Given this list of marker genes CXCR4, UBA6, RAF1, RSBN1, SLC35A2, ST3GAL4, RAMP3, PPP1R15A, EIF1, TMEM109, DHCR7, MORF4L2, NT5C2, ELK3, EIF4A1, HNRNPK, UBE2V2, ETS2, PTGS2, SYVN1, ATG4C, WEE1, LAMTOR5, DLL4, PRKRA, LINC01160, MAP3K8, SOCS3, SFT2D3, EHD1, GCNT1, LASP1, CXCL3, RAB8B, TRIM35, NLK, DNAJC2, YME1L1 (YME1 like 1 ATPase), PABIR1 (PP2A Aalpha (PPP2R1A) and B55A (PPP2R2A) interacting phosphatase regulator 1), KATNBL1, OPLAH, EPS8, HMGCR, CDK2, IFT122, PPA2, IL6, TANC2, MTBP, FBXO11, IZUMO4, IL1B, CSRNP1, VAPA, LDLR, ST3GAL6, RLIM, NBEAL2, VPS51, LRCH1, LLCFC1, WDTC1, HMGA1, PPP2R5A (protein phosphatase 2 regulatory subunit B'alpha), NPLOC4, MATK, PHLDA1, UBA3, EPHA2, HSPE1, ABRACL, CH25H, PIP4P2, KRR1, PPIG, ADAM10, KHSRP, TIFA, PDE4B, VPS8, POLR3C, AFG3L2, MDH1, IER5, ATXN2L, EIF2A, ANXA11, SART1, GPR171, PCMT1, C9orf72, HK1, MLLT3, SERPINB2, TNFAIP3, NFKBID, USP25, TSPYL1, EEF1AKMT2, MPHOSPH9, PRDM1, ATP6V0D1, MSRB3, LCORL, SEPTIN7, CARNS1, DCLRE1A (NCBI Gene Id 9937), ZRANB1, COX11, GNB1, ENY2, GLIS3 (NCBI Gene Id 648268), NXT2, METAP2, RIOK2, MCM2, CDKN1B, RAI2, STK32A, ICAM1, ACTL6A, DNAJC24, GSK3A, ZNF830 (NCBI Gene Id 91603), USP24, RECQL, GEM, MYL9, MAFF, PCGF5, FAM83D, TNF, IRS2, HDAC9, LTA, GBF1, RNPC3, DHX9, GSTO1, ID2, TRAF1, TCOF1, HMGB2 (NCBI Gene Id 3148), GADD45A, MIDEAS, NFKBIB, SCO1, CD86, UFD1, SCRIB, GPR174, TXNRD1, CCDC90B, CCRL2, MAP3K3, IL12B, CHPF2, SAMTOR, BRD3OS, TRAFD1, H1-0, FNIP1, ZFP36, IQSEC1, MARCKSL1, RBM15, RRS1, FAM120A, PHF1, IL1RL2, RAB11A, RAB20, TGIF1, ATP11A, SLC15A3, SMG7, ENPP4, IQCB1, FOXN2, FNBP1L, EZH2, RAB11B, PIK3R2, ADAM8, TNFAIP2, KDM6B, ALDH18A1, TMEM170B, DSE, ACOD1, PAFAH1B1 (platelet activating factor acetylhydrolase 1b regulatory subunit 1), NR4A3, SOWAHC, SMC4, PPP3CA, SARNP, TTYH3, DDX3X, TUBB2B, RYBP, here is a description of the gene set: from publication Ochiai K, Maienschein-Cline M, Simonetti G, Chen J, Rosenthal R, Brink R, Chong AS, Klein U, Dinner AR, Singh H, Sciammas R (PMID 23684984) Temporal analysis of B cell activation in vitro using CD40L and IL-2/4/5 cytokines in wild type Irf4+/+ B cells or in mutant Irf4-/- B cells harboring a tet-inducible allele of Irf4. IRF4 expression was restored, or not, in the Irf4-/- background by culturing in the presence of low or high concentrations of doxycycline. The results provide insight in the role of IRF4 expression levels in coordinating different programs of B cell differentiation. Human Gene Set: GSE46606_UNSTIM_VS_CD40L_IL2_IL5_1DAY_STIMULATED_IRF4MID_SORTED_BCELL_UP Genes up-regulated in at day 0 B cell IRF4-KO versus CD40L and IL-2 IL-4 IL-5 stimulated at day 1 B cell IRF4intermediate. species: Homo sapiens